The following is a description of a gene set: Abnormal trabecular bone morphology Human Gene Set: HP_ABNORMAL_TRABECULAR_BONE_MORPHOLOGY studied in species Homo sapiens Abnormal structure or form of trabecular bone., and this is the list of marker genes: CYP2R1, DKC1, RTEL1, TNFRSF11A (TNF receptor superfamily member 11a), WRAP53, TYMS, PARN, NHP2, TCIRG1 (NCBI Gene Id 8845), NPM1, AXIN1, TNFRSF11B, SLC34A3, TINF2, NOTCH2, DMP1, CTC1, ENPP1, PTH1R, CLCN5, RECQL4, PORCN, ANAPC1, PLCB3, TRPV4, VDR, USB1, NOP10, AMER1, TERC, CYP27B1, TERT, SLC29A3